Given this list of marker genes Arpc2, Pfn2 (NCBI Gene Id 18645), Pfn3, Tmsb15l, Ctnnbip1, Arhgef7, Hcfc1, Nck2, Fchsd1, Ssh2, Ikzf1, Brsk1, Prkcz, Creb1, Pde4dip, Cdc42ep3, Mmp3, Birc2, Trappc12, Zdhhc5, Arhgap28, Ccl26, Gnl3l (NCBI Gene Id 237107), Cdh5, Hmgb1, Kank3, Myadm, Ifi213, Nop53, Rnf4, Cyfip2, Trim9, Tppp2, Plek, Hdac6, Gm14137, Brk1, Stx1b, Snap91, Alox15, Trhr, Lats2, Cav1, Map3k7, Kif21a, Dkk1, Syt11, Septin8, Vasp, Csf3, Mapk15, Arpc5, Capza3, Sptb, Dact1, P2ry12, Nckap1, Pink1 (PTEN induced putative kinase 1), Slf1, Hjurp, Dctn1, Abitram, Ppp2r5b, Grb2, Lmod3, Dnajc15, Myd88, Trp53, Trim31, Lgals3, Eif4ebp1, Senp6, Zdhhc1, Dyrk1a, Traf3ip1, Tlr2, Cldn7, Clu, Ulk1, Slit2, Syk, Arl2, Flii, Pfn1, Tirap, Rab3gap1, Wnt10b, Plcg2, Cck, Hip1r, Ccl21e, Epn1, Ankrd27, Capg, Isg15, Trem2, Rpl13a, Crbn, Ica1, Mapre1 (NCBI Gene Id 99354), P2rx7, Sirt2, Cyrib, Fhod3, Ccl11, Ppp1r9a, Jam3, Vegfa, Dbn1, Unc13b, Arf6, Terf1, Hspa1a, Ddx3x (NCBI Gene Id 236681), Sh3glb1, Caly, Sgk1, Pfn5 (NCBI Gene Id 139668127), Baiap2l1, Add1, Mpp7, Dmtn, Raf1 (v-raf-leukemia viral oncogene 1), Gba2, Ahr, Ptpn11, Dlg1, Tmc8, Camsap3, Clip1, Sptan1, Src, Nav3, Sar1b, Capza2 (capping actin protein of muscle Z-line subunit alpha 2), Svip, Stx1a, Trim30a (NCBI Gene Id 20128), Actr3, Ogt, Ifi208, Ckap5, Washc1 (NCBI Gene Id 68767), Gak, Slain1, Bbs10, Mtln, Ralb, Togaram1, Prune1, Casp4, Isl1, Il5, Bik, Mkks (NCBI Gene Id 99133), Trim11, Hspa8, Csf2, Mlst8, Cdc42ep1, Fbxl2, Farp2, Eif2ak2, Fas, Abca3, Mapt, Eln, Rhoa, Lmo4, Arhgap40, Med25, Ticam1, Trim65, Lmod1 (NCBI Gene Id 93689), Tppp3, Capza1b, Trabd2b, Rasip1, Kcnk13, Scin, Zfp827, Gsn, Dnajc6, Irgm1, Ankra2, Pecam1, Tnf (NCBI Gene Id 21926), Hsf1, Cdc42ep5, Ifi207, Tgfb1, Evl, Hcls1, Git1, Svil, Map3k1, Mapk8, Nol3, Fermt2, Baiap2, Tpm1, Mapre3 (NCBI Gene Id 100732), Capza1, Cdc42ep2, Hck, Brcc3dc, Kank2, Lamp2, Tmsb15b2, Sptbn1 (NCBI Gene Id 268394), Hrk, Atr, Carmil1, Nr1h2, Tmod4, Fmn1, Sar1a, Xaf1, Fchsd2, Bax, Drg1 (developmentally regulated GTP binding protein 1), Mecp2, Ssh3 (NCBI Gene Id 245857), Ulk4, Syp, Selp, Lats1, Ccl24 (C-C motif chemokine ligand 24), Sorl1, Kirrel1, Hes1, Akain1, Dbnl, Prkce, Fscn1, Fkbp4, Hsp90aa1, Stxbp5, Park7, Rhoc (NCBI Gene Id 99594), Mefv, Rab3a, H3f3b, Spidr, Ppp2ca, Thra, Rictor, Lmod2, Pcsk5, Gda, Ankrd53, Stmn2, Lefty1, Abca1, Tfrc, Tal1, Abl1, Pycard, Ep300, Ptk2b, Slf2, Tfip11, Pik3r2, Igtp, Prkcd, Arhgef2, Tbcd, Vil1, Mmp1b, Napa, Ssh1, Ajuba, Ccl21f, Cd36, Vdac2, Jmjd6, Slc39a12, Kank4, Mtor, Fblim1, Stub1, Dut, Btk (Bruton agammaglobulinemia tyrosine kinase), Lcp1, Tenm1, Ifi203-ps, D1Pas1, Cptp, Cdk5rap2, Snca, Capzb, Akap9, Ttbk1, Cdc42ep4, Met, Abhd17a, Kif9, Hspa1b, Esam, Rdx, Unc13a, Napb, Dab2ip, Map1b, Nrg1, Mavs, Zdhhc12, Cyria, Eml2, Arfgef1, Sox9, Icam1, Brcc3, Rap1b, Foxc2, Gba1, Map2, Arhgap18, Pex5, Psrc1, Tnfsf18, Pak3, Rack1, Cav3, Mmp1a, Pak1, Stxbp1, Fermt1, Preb, Snx9, Cttn, Coro1a, Inpp5j, Faf1, Ncam1, Syngr3, Hax1, Wars1, Nckap1l, Tlr6, Eif4g1, Gbp5, Gm12250, Tmsb4x, Avil, Plekhg2, Sec16a, Cd24a, Aida, Clec7a, Bcl2l11, Hspa5, Skap1 (NCBI Gene Id 78473), Myh9, Vill, Fnip2, Bbs4, Kank1, Atm (NCBI Gene Id 77416), Myo1c, Gsk3b, Nck1, Spta1, Ublcp1, Atat1, Tmod2, Nme7, Bak1, Kif14, Bmf, Stxbp6, Eps8, Cryab, Dhx33, Ifng, Carmil2, Prkd1, Cxcl13, Camsap1, Capn1, Psmc6, Fnip1, Ifi214, Nlrc3, Usp50, Apc, Cfl1, Osbpl2, Cand1, Arhgef5, Riok3, Tubb4a, Ccl21a, Add3, Insm1, Ptger4, Mtpn, Gbp2, Stmp1, Baiap2l2, Stmn1, Ikbke, Vcp, Ptpn22, Csnk1a1, Rasa1, Sost, Tmod3, Nphs1, Tppp, Rps3, Ifi203, Msn, Fes, Bid, Vps35, Bin1, Cracd, Mapk9, Clec2i, Camsap2, Arpc3, Cdc42, Sumo1, Rims1, Mndal, Lcat, Ice1, Fer, Prex1, Traf2, Arpc5l, Piezo1, Apoe, Cotl1, Clasp2, Ccl21b, Numa1, Twf1, Add2, Daam2, Ifi209, Rac1, Ccl21d, Lcmt1, Ifi206, Bag4, Cyfip1, Hrg, Cdh17, Bbc3, Cdkn1b, Clip3, Tmod1, Twf2, Tlr4, Ambra1, Irgm2, Ncln, Slain2, Nek7, Oprd1, Prrt2, Mark4, here is a description of the gene set: studied in species Mus musculus Any process that modulates the frequency, rate or extent of protein complex assembly. Mouse Gene Set: GOBP_REGULATION_OF_PROTEIN_CONTAINING_COMPLEX_ASSEMBLY